The following is a description of a gene set: species: Homo sapiens from publication Chen Y, Wang X (PMID 31504780) Human Gene Set: MIR12131 Genes predicted to be targets of miRBase v22 microRNA hsa-miR-12131 in miRDB v6.0 with MirTarget v4 prediction scores > 80 (high confidence targets)., and this is the list of marker genes: CALM1, TBL1X, WDR26, PUM2, TRMT9B, CD276, CALCR, MYOZ2, CATSPERE, KIF1B, MCM8, TC2N, PLAGL1, POLI, SMARCAD1, SPIN1, ZBTB26, PPARD, TRPM7, STEAP2, CUL4B, ZNF24, LRRC31, GALNT7, OTX1, DDX6, CCDC74B, ZNF175, MPV17L, TMPO, SPATA31F3 (SPATA31 subfamily F member 3), TMEM254, ELP1, ATF7IP, CAMK4, TXNRD2, PAX5, ZFP82, ANKRD44, ZCCHC14, ADAM10, PEF1, TMEM43, C15orf40, HNRNPU, TMPRSS13, BMP2, KIAA1549, LIN9, MMP16, TWF1, CSRNP3, SMIM8, MED17, STAG2, CCDC74A, GPR26, CADPS2, EIF4B, CD209, CHRDL1, IKZF2 (NCBI Gene Id 51173), DCX, BORCS7, CHSY1, SPATA6L, SP100, CNOT7, SVIP, CALN1 (NCBI Gene Id 83698), USP33, GTDC1, TSPAN4, SLITRK2, CYSLTR2, ZDHHC2, SORL1, SYNJ1, SRD5A3, NDUFB5, AFP, ERCC6, ITPK1, CWC15, B9D1, IFI44L, SESN1, FOXM1, PITPNC1, DCHS2, GID4, HLCS, HPSE2, ACTBL2, OLFM3, PDE12, SENP5, DOK3, SVBP, WDHD1 (WD repeat and HMG-box DNA binding protein 1), SGMS1, PRKCE, PAFAH1B2, SHTN1, ZNF704, SYN1, PIK3CB, EPHA6, CELF2, TOX3, CCL22, MMD, SMCO4, ATP10D, INTS6, PTER, PRSS37, VCF1, EMB, LYST, ZNF385D, BACE1, FOXO3, THOC5, HOXD13, CRTAP, NAA50, ZDHHC15, TBC1D4, DIXDC1 (DIX domain containing 1), MARCHF5, NPC1, FBXO28, ENTPD7, CEACAM1, LPL, ADI1, PWWP3B, ABLIM1, KLHDC3, TESC, EPHA4, MSANTD3 (NCBI Gene Id 91283), PITPNB, TPD52L1, PDE1C, ZNF555, COL4A1, GPATCH2L, PALM2AKAP2, ELL, APELA, ALPK3, TCF20, ELMOD2, CLDN11, THSD7A, BNC2, ENTPD3, ZSCAN30, SDF2, NEXMIF, SV2B, ISOC1 (NCBI Gene Id 51015), F8, DIS3, XKR9, TANGO6 (transport and golgi organization 6 homolog), AAK1, DISP2, ARMC3, GLI2, COLEC11, COPS4, ULK4